The following is a description of a gene set: A form of hepatic steatosis characterized by the presence of small, lipid-laden vesicles in the affected hepatocytes. Human Gene Set: HP_MICROVESICULAR_HEPATIC_STEATOSIS Microvesicular hepatic steatosis species: Homo sapiens, and this is the list of marker genes: CARS2, MRPL44, LRPPRC, TRMU, PIGA, DNAJC19, BCS1L, TFAM, TOMM7, YARS1, UNC45A, POLG, LYRM4, SLC25A13, MPV17, SLC22A5, NHLRC2, VPS4A, ACAD9, POLG2, NGLY1, NAA10